Given this list of marker genes PRKAR1A, RAPGEF2, PRKAR1B, RAPGEF4, PDE4D, PDE10A, PDE4B, HCN4, CNGA1, POPDC3, CNGA2, HCN3, BVES, CNGB1, HCN1, PRKAR2A, PDE2A, CNGA4, PRKAR2B, PDE4A, CNBD2, RAPGEF3, POPDC2, HCN2 (hyperpolarization activated cyclic nucleotide gated potassium and sodium channel 2), here is a description of the gene set: Human Gene Set: GOMF_CAMP_BINDING Binding to cAMP, the nucleotide cyclic AMP (adenosine 3',5'-cyclophosphate). species: Homo sapiens